Given this list of marker genes CD46, SERPINA6, FOXA2, LMNB1, TBX19, HEXB (hexosaminidase subunit beta), SOX3, CHRNA3 (NCBI Gene Id 1136), TXNRD2, IL12RB1, CYP11B2, CAV1, HESX1, CLCNKB, MC2R, CFH, LEPR, SIM1, B2M, SLC25A20, ACE, ATP7A, KIT, IL12A, STAR, GLI2, SAA1, NFKB2, PROP1, AGTR1, ACAT1, IRF5, KYNU, POU2AF1 (NCBI Gene Id 5450), HMGCL, MMACHC, SCNN1B, SRSF2, RUNX1, MUC1, RYR1, COL1A1, TTR, HADHB, ASXL1, TNPO3, COL5A2, ELP1, PSAP, DBH, EIF4G1, OTX2, GSN, AIP, SERPING1, HELLPAR, PRDX1, GBA1, LRRK2, ABCA3, MRAP, SFTPB, COQ2, REN, AGT, VPS35, TNNT2, CYP11A1, LEP, TRAPPC11, MEN1, GMPPA, PDE4D, SCNN1A, ALB, IRF4, VHL, CASR, SLC12A1, CYB561, DNAJC13, TNFSF15, SFTPC, FMR1, CHCHD2 (NCBI Gene Id 92547), ATRX, GIGYF2, SLC12A3, GNA11, ARSA, KCNJ1, AAAS, GBE1, SPG11, CDH23, COL5A1, SNCA, DCTN1, TET2 (NCBI Gene Id 57667), NNT, LHX4, MMEL1, NR3C2, PRKAG2, NTRK1, DDC, SPIB (Spi-B transcription factor), CBL, POU1F1, HSD3B2, ACBD6, CFI, here is a description of the gene set: Human Gene Set: HP_HYPOTENSION Hypotension studied in species Homo sapiens Low Blood Pressure, vascular hypotension.